The following is a description of a gene set: This event has been computationally inferred from an event that has been demonstrated in another species.<p>The inference is based on the homology mapping from PANTHER. Briefly, reactions for which all involved PhysicalEntities (in input, output and catalyst) have a mapped orthologue/paralogue (for complexes at least 75% of components must have a mapping) are inferred to the other species. part of: Membrane Trafficking electronically inferred by orthology from the curated human pathway Reactome Pathway: Clathrin-mediated endocytosis species: Mus musculus, and this is the list of marker genes: Pacsin2 (NCBI Gene Id 23970), Actr2, Syt8, Nedd8, Gak, Igf2r, Grk3, Grb2, Ubqln2, Ap2b1, Picalm, Syt9, Ubb, Ap2s1, Arrb2, Areg, Egfr, Btc, Vamp2, Apob, Epn1, Trip10, Sh3gl3, Ldlr, Snx9, Rps27a, Bin1, Arf6, Epgn, Amph, Ap2a1, Fcho2, Vamp4, Dnm2, Avpr2, Necap1, Hip1r, Snap91 (synaptosomal-associated protein 91), Cd3d (CD3 antigen, delta polypeptide), Arpc2, Cltb, Tor1a, Cops6, Cd3g, Arpc4, Syt1, Slc2a8 (NCBI Gene Id 56017), Eps15l1, Pip5k1c, Synj2, Itsn1, Arpc5, Trf, Avp, M6pr, Pik3c2a, Fzd4, Rab5c, Chrm2, Vamp8, Tacr1, Dvl2, Dnajc6 (DnaJ heat shock protein family (Hsp40) member C6), Ap2m1, Stam (NCBI Gene Id 20844), Cbl (Casitas B-lineage lymphoma), Tgfa, Ocrl, Reps1, Actr3